The following is a description of a gene set: from publication Chen Y, Wang X (PMID 31504780) Genes predicted to be targets of miRBase v22 microRNA hsa-miR-767-5p in miRDB v6.0 with MirTarget v4 prediction scores > 80 (high confidence targets). Human Gene Set: MIR767_5P species: Homo sapiens, and this is the list of marker genes: NAV3, MYCN, GXYLT2, PPM1D, TBL1XR1, CRISPLD1, RAI14, VHL, DBT, FOXJ2, XPO4, NAV1, ZNF644, PI15, CCDC50, MLF1, CSDE1 (cold shock domain containing E1), GRIA3, BASP1, NLK, TAF5, SEC31B, COL6A3, PXYLP1, GOLGA1, STX16, NONO, IFFO2, DAZAP2, KLF2, CAMK4, COL4A4, SPC24, XKR4, PPP4R3B, KLHL28, MTRFR, DIP2C, SLC4A8, COL11A1, SEPSECS, TUBB2A, PAN2, CPS1, HBP1, TET3, LOX, C11orf24, ANKRD13B, GINS1, MORF4L2, CCDC43, INPP5A, HYCC2, STMN2, GPX7, ADAM12, COL4A1, SERTAD2, ADAMTS3, MORF4L1, ADAM17, NDUFS4, BTLA, AP4E1, BACH2, POGLUT2, BABAM2, PPP1R13B, MBTD1, NCKAP5 (NCK associated protein 5), SMIM13, USP42, OVOL2, PLEKHG3, SUMO1, ACSM5, ATRN, RND3 (NCBI Gene Id 390), RPS6KB1, SLC16A14, STK38, ZFX, GPATCH2, OSBPL11, NAV2, PEG10, HAPLN3, LRRC8B (NCBI Gene Id 23507), NEXMIF, TTC9, HOXD10, PRKAB2, TET1, DDX5, PPP1R15B, CYP39A1, FNIP2, PPM1E, OTUD4, TMTC3, ATP2B4, ZNF382, IREB2, CLDN11, PLG, TMEM169, DPYSL5, CMPK1, SOCS2, IFT70B, RIMS2, COL2A1, CACNA2D3, TCF7L2, HIP1 (huntingtin interacting protein 1), KLF6, TNRC18, CCDC186, COL5A3, NFIA, SETDB2, KIF26B, ISG20L2, RPP25, DGKD, SESTD1, TLL1, HMCN1, LDLRAD4, DCC, OTULIN, HS3ST3B1, PHTF2, TMEM236 (transmembrane protein 236), FUT8, UBE2Z, AHR (aryl hydrocarbon receptor), EPHA5, ARHGEF5, NCOA4, HMGCS1, FOXE1, SCAI, FBN2, CBLL1, EML6, SMAD6, RNF138, CCNYL1, WDFY1, ZNF282, SPOCK3, ASXL3, SNX1, TRIB2, USP6NL, RNF19A, CAMSAP2, NAP1L5, BLMH, VPS37C, DOP1A, CUX1, PMP22, N4BP2L1, TMEM88 (transmembrane protein 88), ASB8, COL3A1, EPS15, EAF1, FNDC5, PTPRK, PANK1, MOSMO, EIF4E2, GRIP1, IFI30, MATCAP2, CRISP2, CAMKK2, SSC4D, PALM2AKAP2, OSTC (oligosaccharyltransferase complex non-catalytic subunit), SH3GLB1, DNMT3A, TNRC6B, SMAP1, FUCA2 (alpha-L-fucosidase 2), KLF4, IL1RAP